The following is a description of a gene set: Mouse Gene Set: REACTOME_SIGNALING_BY_NOTCH species: Mus musculus Signaling by NOTCH, and this is the list of marker genes: Jag1, Akt1 (thymoma viral proto-oncogene 1), Dtx4, Maml1, Aph1b, Dtx2, Psen1, Psenen, Prkci, Ybx1, Aph1a, Dll4, Elf3 (NCBI Gene Id 13710), Egf (epidermal growth factor), Dtx1, Egfr, Uba52rt, Ywhaz, Mamld1, Notch4, Jag2, Kat2a, Wwp2, Kat2b, Rps27a, Furin, Itch, Maml2, Rbpj, Ep300, Tmed2, Dll1, Ubb, Uba52, Ubc, Ncstn, Maml3, Adam10, Notch1, Notch3